The following is a description of a gene set: studied in species Homo sapiens The directed movement of a protein to a specific location in a membrane. Human Gene Set: GOBP_ESTABLISHMENT_OF_PROTEIN_LOCALIZATION_TO_MEMBRANE, and this is the list of marker genes: ATP13A1, ZDHHC2, MTCH1, NCF1, MACF1, COX18, GOLGA7B, RAB26, EMC1, HPCA, SIL1, RAB3GAP2, NACA4P, ITGB1BP1, RAB3GAP1, EMC8 (NCBI Gene Id 751), AQP11, SAMM50, ITGAM, ZDHHC24, BBS2, CHMP4B, SEC61G, SRP72, ZDHHC14, CWH43, CIB1, NOMO3, GRIP2, BAX, TIMM8A, ARL6IP1, SSR1, TIMM29, ZDHHC3, NACAD, RTP2, NACA, MTCH2, CPLX1, VPS37B, PRNP, ZDHHC21, TOMM6 (translocase of outer mitochondrial membrane 6), YIF1B, SRP19, RFTN1, SCARB2, CLN3, RAB11FIP3, NPC1, SPTBN1, EMC3, CHP1, SRP9, NSF, RAB11A, HSPA5, REEP1, CEMIP, GRIP1, INPP5K, GGA2, RILPL1, SRPRA, RAB11B, CD24, GRIPAP1, GOLPH3, SLC51B, TIMM10, FRMPD1, MTCL1, MTX1, PEX19, ROMO1, GET3, GJD2-DT, KCNE1, MTX2, ANKRD13C, CAMLG, UMOD, TCAF1, RACK1, WDR83OS, TOMM70, GOLPH3L, SRPRB, GOLGA7, ARL6, KCNB1, BBS1, BAG6, VAMP5, GET1, RAB8A, NSG1, CCDC47, KRT18, AGK, C2CD5, SYS1, ZDHHC23 (zinc finger DHHC-type palmitoyltransferase 23), RAB3IP, TOMM40, AP3B1, SCRIB, USP17L2, ITGB2, CLSTN1, PDZK1, CDK5R1, RILPL2, ARHGAP44, BHLHE40-AS1, RTP4, EMC9, PREPL, PIKFYVE, NOMO2, ZDHHC15 (zinc finger DHHC-type palmitoyltransferase 15), DMTN, TIMM9, RAB10, UBL4A, SSR2, RABGEF1, RAB8B, RDX, SGTA, RTP1, ERBB2, GLP1R, RN7SL2, LRRC7, ZDHHC9, ZDHHC12, GCC2, VPS35, ZDHHC1, AKT2, GOLGA4, NDUFA13, ATG3, SLC1A1, ANXA13, LARGE1, RTP5, VAMP4, SRP54, REEP2, WNK1, SEC62, ARFRP1, VPS37D, TCAF2, RAB34, ZDHHC19, TRARG1, NOMO1, RTP3, TIMM22, BRAF, SGTB, SNAP25-AS1, VPS37A, TRMT10B, TOMM7, RSC1A1 (regulator of solute carriers 1), VAMP3, GET4, ACSL3, TIMM13, MAIP1, GGA1, SORL1, MIEF2 (NCBI Gene Id 140774), TIMM8B, SEC61A2, MMGT1, PHAF1, PRKCI, MYO1C, ATP6AP1, RAB31, SEC63, ZFAND2B, TAOK2, NCLN, RAB5IF, EMC4, RN7SL3, TMEM126A, KIF13A, FYN, ZDHHC20, ZDHHC11, TRAM1L1, NECTIN3, GDI1, ANK3, ATP2C1, GORASP1, PEX26, MAL, TTC9-DT, SEC61B, TIMM10B, PAK1, ZDHHC6, ATP1B1, COLQ, MOAP1, GGA3, TRAM2, TOMM20, GORASP2, SACM1L, ZDHHC18, STOM, SDCBP, STX3, CACNG2, EGFR, CDK5, PEX5, CALM3, BLZF1, BCS1L, ADORA1, VAMP2, AMN, MICALL1, CHMP4A, TRAM1, AKAP5, EMC6, LYPLA1, RAB7A (RAB7A, member RAS oncogene family), CSK, PEX16, RAPSN, NACA2, RN7SL1, EMC7, CHM, SRP14, ICMT (NCBI Gene Id 57087), SRP68, MIEF1 (mitochondrial elongation factor 1), PEX3, ZDHHC7, COMMD1, LYPLAL1, PKDCC, SEC61A1, SYNE3, OXA1L, ZDHHC4, ZDHHC11B (NCBI Gene Id 653082), ENSG00000283175, VPS37C, HRAS, TOMM5, TOMM22, TMEM147, ZDHHC22, EMC2, CNST, BID, OPTN, SSR3, PARD3, TMCO1, ATAD1, GRIN3B, EMC10, AFDN